Given this list of marker genes SLC37A4, COX6B1, GCDH, PHKA2, PHKG2, here is a description of the gene set: Hyperketonemia Human Gene Set: HP_HYPERKETONEMIA An increase in the level of ketone bodies (acetoacetic acid, beta-hydroxybutyric acid, and acetone) in the blood. species: Homo sapiens